The following is a description of a gene set: Three innate (B1-B, NKT, CD8aaT cells) and adaptive (B2-B, CD4T, CD8abT cells) cell-types were sorted by FACS. Three biological replicates for NKT, CD4T, CD8aaT, CD8abT cells and two biological replicates for B1 and B2 cells were generated and the expression profiles were determined using Affymetrix Mu74Av2 chip. Comparisons between the sample groups allow the identification of genes differentially expressed between the innate and adaptive cell-types. species: Homo sapiens from publication Yamagata T, Benoist C, Mathis D (PMID 16623764) Human Gene Set: GSE3039_ALPHABETA_CD8_TCELL_VS_B2_BCELL_UP Genes up-regulated in CD8A CD8B versus B2 B lymphocytes., and this is the list of marker genes: GDI1, TUBGCP6, KLF15, L1CAM, SLC9A9, ACKR1 (atypical chemokine receptor 1 (Duffy blood group)), RAPGEF6, NAV1, PAPSS2, UBAC2, ARMC3, CTNND2, TNFRSF4 (NCBI Gene Id 7293), CD180, LTF, IRAG2, PLA2G15, RASA3, PARP8, STRIP2, TMEM123, GRAMD2B, ANP32A, UNC13D, CNP, SEPSECS, CNTRL, TYK2, MYB, PALM, SIN3A, ANGPTL1, EIF3A, STX16, FBXL6, ARID4A, ADD3, ZNF646, ATP10D, EVL, PIK3R4, TAF8, MARK3, ABCA7, CACNA1S, PRP4K, CLK1, CCR9, FHIP1B, SLC6A13, OGFRL1, UBXN2A, SLC22A23, ARHGEF37, ARMC8, ATP2A3, PTP4A2, TMEM178A, SPG11, CYP27A1, FCRLA, RBBP8, CACNB3, GIMAP4, CYFIP2, PRDM15, RBM27, ANKRD12, DOP1A, CCDC25, PCMTD2, TMEM150C, VAV2, TSPYL4, RICTOR, OMA1, PMS2, SERPINI1, HLA-G, CELF2, PURG, ABCD1, HERPUD1, MAN1A1, DFFB, ABCB10, FRAT2, ENTPD6, AP3M2, SEMA6D, USP4, TUT4, CRIP2, RAB38, MLST8, DCAF17, PADI2 (peptidyl arginine deiminase 2), EP300, PPOX, MPP7 (MAGUK p55 scaffold protein 7), MLLT10, UBXN2B, ZMYND8, ARID1A, PARP14, EPB41L3, CFAP141, RGS18, AMZ1, DPY19L1, CDC42EP3, SLFN12L, SHLD1, LIME1, SZT2, ERN1, PANK4, CYLD, ATP1B1, AMPD3, AKNA (NCBI Gene Id 80709), TMT1A, EXTL1, TMCC1, ZNF518A, ZNF329, ZNF740, C6, PPM1H, ZC3H12D, CCDC88A, ARAP3, SNRK, TATDN3, NUFIP2, PTPRCAP, AFMID, PIAS3, CBL, PPP4R3A, CIB1, RPS6KA1, LBR, UBE2F, GZMA, TOP2B, ELF2, CIPC, HECA, SCARB1, DCP2, PLAC8, MADD, JMJD1C, BZW2, BBS9, GATA1, ENSG00000267882, NUP210, PRIMPOL, KRIT1, CLEC4G, BCL6, CLCN4, KIF21B, NKG7 (natural killer cell granule protein 7), LENG9, VCPIP1, TMEM108 (transmembrane protein 108), CDS2, RPL13A, CCDC88C, CREBRF, FYCO1, CCDC97, DHRS7, SMG1, IRF9, IER5, RIPOR2, ERBB4, IL31RA, TTI1, HSD17B8, ARAP1, IQGAP2, GIMAP6, TDRD7, PARVG, ZKSCAN3, MYO9A, PIK3CD, BMX, PHAF1, NRROS, NCOR1, DENND2D, EBF1, CCND3